Given this list of marker genes RPL21, sfaS, trxA, LTF, eis, botG, GTF2E2, TLR2, PRMT1, BECN1, CNBP, AP2M1, GBF1, DDOST, RPS15, ggtA, MED22, SNAP25, ANO5, esxA, TUBA4A, emrE, GNAT3, PSMC3, SV2C, UL114, PARP10, PACS1, MRC1, P4HB, ZDHHC11, RPS21, TRM1, FXYD7 (FXYD domain containing ion transport regulator 7), ARPC3, TAB1, SF3B2, ITCH, STT3A, UL41A, DDX20 (NCBI Gene Id 51452), RBX1, HERC5, POLR2D, RPS27 (NCBI Gene Id 6232), BCL2L1, MGAT4C, SPCS1, TAF4, PRR5, CAMK2D, UL4, TSG101, PPP1CC, ADCY4, AP1S3, bamD, CRB3, IGKV3D-20, UL48, SRSF3, mdfA, efeU, IGLV3-25, 16S rRNA, KPC-2, MVB12B (NCBI Gene Id 89853), IGLV8-61, SMAD3, MED6, LARP1, ANO2, GPC4, PYCARD, IGKV1D-16, MYO9B, ARID4B, BRMS1, feoB, IFNA6, CORO1A (NCBI Gene Id 11151), RPS4Y2, PPIH, RIPK3, CYSLTR1, vpr, DYNC1LI1, F2, RPS28, CBL, LY96, HNRNPU, TJP1, DHX9, FEN1, UL71, EIF4G2, CAMK2A, fepB, CDK7, IGHV4-34, ARID4A, lpdC, HLA-C, LIG1 (NCBI Gene Id 3978), US11, TRAF6, UL21A, bla, MED23, ptpA, hlyD, RPL36AL, ELMO2, GTF2A2, ARPC1B, AP1B1, trxB, UL94, GBP4, POLR2C, IL1A, ENTPD5, SRSF9, MAN2A1, ACTR2, SIGMAR1, CTSG, NEC1, MAPKAP1, 8, TAF11, NUP107, MYO10, LAMB3, secA1, RPL26L1, CTNNBL1, SNRPD1, ZDHHC8, AP2A1, SNRPD3, E, MED18, SMNDC1, H2BC17, RPL7, POLR2L, 8b, RPL22, TRIM27, ATG7, CDK8, 5.8S rRNA, ELAVL1, CCNK, inlA, lepB, IGKV1-16, mdtE, TUBA1C, RB1, CHERP (calcium homeostasis endoplasmic reticulum protein), RCOR1, 18S rRNA, GEMIN4 (gem nuclear organelle associated protein 4), SNRPB2, 1a, acrB, NCK1, IGKV3-15, NFKBIA, ZCRB1, SYT1, RPS23, TUBB2B, RNA4.9, SNF8, PSMA3, UL95, UL111A, SEC24D, RPL37A, 7SL RNA (ENSG00000222639), ADCY2, PROS1, exbD, US17, HCK (NCBI Gene Id 3055), VPS37D, HNRNPA3, VPS33B, IGLV1-36, FURIN, UL103, CHD3, ARF1, NOS2, UBA6, ntnha, CRNKL1, LPG1G2, CXCR4, ABI1, PLCG2, FIP1L1 (NCBI Gene Id 81608), SRSF6, NUP85, H2AC25, MAP2K2, GNAI2, YWHAZ, TBP, UBE2I, GNG3, CLDN1, VTN, RPLP0, MVB12A (NCBI Gene Id 93343), yqjI, IGHV4-39, GGT5, ARIH1, WAS, SUGT1, bfrB, RPS29, DYNLL2, TUBA3E, CSTF1, UL54, IMPDH1, CREB1, RBM10, PSMD3, BAG2, IFNA17, TAF3, nef, chuA, FXYD6, RPL38, MNAT1, PIK3R1, rpoA, PPP1CB (NCBI Gene Id 5500), SNRNP40, lef, CD163, tetX, PLK2, UL34, POLR2H, IGHV7-81, UL52, CHMP1A, UL9, PTK2 (NCBI Gene Id 5747), fecE, APOBEC3G, IGLV1-40, SNRPB, IFNA4, TUBA3D, IGKV3-20, CRK, LAMA3, PSMD13, TAF5, HDLBP, XAB2, efeO, RNF135, CUL5, RPL18, FXYD4, U2AF1 (NCBI Gene Id 7309), IGF1R, HDAC1, RPL27A, NFE2L2, UL147, IGKV5-2, JAK1, UL25, NCBP1, IGHV, NOD1, C4BPB, IFIH1, SLC25A5, IRF7, FXYD3, SFTPD, NUP54, UL92, GPC2, TBL1XR1, SNRPD2 (NCBI Gene Id 6633), PDPK1, ABI2, LAMB1, SUMO1, PHF5A, EXOC1, IGHV4-59, HLA-A, RAB5A, P2RX4, L, IFNA8, dppF, RPTOR, CWC27, MED28, IL6, GSDMD, fhuD, CCNT1, DYNLL1, SPCS3, RAE1, oppC, PRPF8, MED7, RPL41, SUN2 (NCBI Gene Id 25777), RPL3L, PHF21A (PHD finger protein 21A), NFKBIB, IGLV3-1, HMOX1, GPC6, RIR1, RNGTT, HLA-B, RPL4, rmtD, ERCC3, MLKL, MGAT4B, UL38, HA-33, dppC, IMPDH2, UL102, GGT1, HYOU1, SDC2, IGKV2D-40, dppB, CHMP5, SAP18, ENTPD1, PCF11, VPS41 (NCBI Gene Id 27072), TUBB4B, MED11, PDCD1, IFNA14, MED16, HLA-H, DPM3, trx-2, Hh5 strain Merlin complete genome, CALR, IGHG2, SYK, RPL32, P2RX7, RL11, PSIP1, IFNAR1, SEM1, rev, RPL13, NLRP3, MAP2K4, VAV2, IGHG1, H2AC11, UL148, REST, US20, znuC, US28, TUFM (NCBI Gene Id 7284), MERTK, TXNL4A, S, tonB, DHX15, GAS6 (NCBI Gene Id 2621), UL132, UL133, IGLV5-37, FNTA, H2BC13, HNRNPA2B1, MED1, PUF60, PPIL3, esxG, M, secG, PARP9, IGLV6-57, SUDS3, GTF2H4, AP1S2 (adaptor related protein complex 1 subunit sigma 2), FCGR2A, CD4, PPIL4, RPL7A, NS, RIPK2, RPL19, GBP1, fecB, IGLV2-11, rep, WASF2, BAIAP2, SF3B5, PPE2, SRRT, AHCYL1, ARPC1A (actin related protein 2/3 complex subunit 1A), gspS2, NUP214, WDR33, TAF1L, DYNC1I2, inlB, RPL12, SPCS2, UL70, ST3GAL4, HSPA1A, RPL24, IGKV2D-28, GATAD2A, PKLR, HNRNPL, MED9, GEMIN2, DYNLT1, CD28, US18, UL69, GNG4, CHMP4C, US24, XRN1, NUP188, MGAT5, ELK1, IGHV2-70, NCOR2, CCNT2, botA, HSPG2, RIPK1, RPS25, RL1, H2AC21, TAF6, NUP37, JAK2 (NCBI Gene Id 3717), SEC24C, AKT1, RPL10A, gB, glbN, PB1, TOMM70, aldR, IGHV3-30, ARPC4 (NCBI Gene Id 10093), TUBAL3, 7a, rmtC, LEO1, N, CLU, IGLV2-18, skp, ITPR3, UL32, RPL34 (NCBI Gene Id 6164), VPS28, DOCK2, IGHV3-9, sta2, CAMK2B, DHX38, bfr, NEDD4L, UBA52, TRX2, PRCC, IGKV3-11, H2BC9, PIK3R4, RPL23, tolC, irtB, rmtG, PSMA6, sodC, TRAF3, EEF2, SRPK1, IGLV3-12, ARPC2, 1C, EEF1A1, SH3KBP1, M2-1, GNGT2, CSNK1A1, PTBP1, MEFV, KPNA5, bamA, UL79, UBA5, RPS3A, UL44, IGLV1-51, TAF9, CPSF4, DPM2 (NCBI Gene Id 8818), RPL37 (NCBI Gene Id 6167), GPC3, PCBP1, ATG14, mdtF, KPNB1, MTA3, ahpD, US3, RPS6, IFNAR2, PRPF6, HBB, DOCK1, CD79A, CD2BP2, ITGB1, PSMC6, SDC4 (syndecan 4), COL4A3, PRKG2, AP1S1, NUP133, HLA-E, HSPA1B, UL84, gyrA, IGLV, GNB3, ybtP, NMT2, fhuC, VPS18, gspC2, RAB7A, UL88, CYSLTR2, KEAP1, ST6GAL1, CDK9, RPS27A, CBX1, SMN1, TXNRD1, UBB, GALNT1, RL10, MAPRE3, TRM3, RBM22, TGFB1, rpoC, RPL6, MED20, HNRNPH2, H2BC14, UBE2L6 (NCBI Gene Id 9246), GNG12 (NCBI Gene Id 55970), HNRNPR, SEC24B, FKBP4, NRBP1, US12, IGKV1D-12, DPEP1, IRAK2, C1QA, MTA1, NP, NCOR1, IGLC6, IGHV3-48, PSMD11, SEC11A, IRAK1, MGAT1, RCAN3, UL147A, LAMA2, NUP58, WASF1 (WASP family member 1), RPL39, RBBP4, DAD1, armA, MOGS, IGLV2-8, mppA, UBA7, BLNK, POLR2A, bcsQ, DUSP16, POLR2F, mdtA, VPS16, POLR2G, H2BC11, PSMB4, SV2B, NCKAP1, MED24, PA, UL74, 9b, NUP93, sta1, FCGR3A, IL17RA, MED12, POLR2E, gL, IFNA1, pef, PEX19, UL80, POLR2K, VPS45, IGKV2-30 (immunoglobulin kappa variable 2-30), ADORA2B, TRS1, GRPEL1, MAPK14, TUBB4A, IKBKG, surA, degP, UL122, CD8B, TBL1X, SEC11C, ITPR1, DYNC1H1, TAF15, SKP1, MED25, IGKV4-1, secD, NUP153, AQR, SH3GL3, PSMB2, ELAVL2, TAB3, UL22A, SH3GL1, H2AC6, US34, ANO6, H2BC5, ATP6V1H, SUPT4H1, HNRNPH1, H2AC7, GPC1, UL97, VPS11, UL99, RL8A, fecD, IGLV7-43, C4B, MED8, IL1B, TUBB1, ANO10, PRKAR1A, NCL, TUBB8B, SF3A1, IFNA10, secA2, GNB5, MT2748, RPS13, VPS25, IRS1, TLR6 (toll like receptor 6), RPL11, SV2A, MED17, OST4, US27, FXYD2, JAK3, RPL30, UL14, GSK3A, PARP1, VPS37C, ZDHHC3, PPIL6, TAF10, BUD31, VAV3, NELFE, NELFB, Rv3655c, MAP2K1, CCR5, CD209, CAMK2G, MAP1B, UL2, Human respiratory syncytial virus A, BRK1, ROCK1, YES1, RPS7, UL138, TIMD4 (NCBI Gene Id 91937), NUP42, PSMD12, PSMD14, KPNA7, PARP6, STT3B, TAF1 (TATA-box binding protein associated factor 1), NMT1, rmtH, CTNND1, SRRM1, NUP50, NOX1, ahpC, NPM1, BTK, TLR4, GNB2, Rv2895c, PPIE, IFNGR1, TMPRSS2, MAP2K3, GTF2F2 (NCBI Gene Id 2963), MED4, DPM1, RL9A, PABPN1, RPL31 (ribosomal protein L31), GTF2H5, RCC1 (NCBI Gene Id 751867), PSMB7, mdtB, US2, RBBP7, bamC, RPL9, CYFIP1, CPSF2, H2BC15, RPL26, CHMP2A, B2M, CHMP4A, CLP1, AXL, 5S rRNA, RICTOR, GBP2, csgA, GNGT1, COL5A2, rpoZ, UL82, MED21, POLR2I, PSMA7, CWC15, IGLV7-46, MED10, PTPN11, CLINT1 (NCBI Gene Id 9685), fkpA, PRPF19, BCAP31, MTA2, NOD2, fes, UL5, H2BC21, DYNC1I1, ADRM1, DNAJC8 (DnaJ heat shock protein family (Hsp40) member C8), TUBB3, TCEA1, IGLV3-16, RPL23A, PABPC1, UL16, VPS37A (VPS37A subunit of ESCRT-I), MED14, COL4A5, SAR1B, VPS4A, WIPF3, ZDHHC5, UTI89_C2180, RPS14, RBMX, EIF4E3, Rv3654c, P4HA1, H2AC14, vpu, DAXX, NT5E, YWHAE, U2AF1L4, BTF3, nleF, TUBA8, oppB, TUBA3C, IL10, PSMC2, SF3B4, CCNH, cya, GTF2A1, acrD, tat, pagA, CD247, GBP6, ha17, TLR9, NUP205, CX3CR1, 1B, tetA, TAOK1, GNG8, fecA, COL4A2, IGHV2-5, UBE2V1, IFNA21, gM, XRCC5, DNAJC3, VPS4B, WBP11, EIF4A2, CHMP3, IGLV4-60, NELFA, GNB4, RPS19, 28S rRNA, SEH1L, PLCG1, DNAJA2, UL23, GRSF1, UL124, PSMD7, PAF1 (NCBI Gene Id 54623), CWC25, UBR4, TLR8 (toll like receptor 8), STAT2, UL146, RPS8, CLTC, MASP1, gdx, EIF4G3, VTA1, ALYREF, MET, IL17RC, TRX1, GTF2F1, SUZ12, UL112/UL113, UVRAG, eltB, ISG15, CHMP6, FUT8, oppD, CDH1, RPL8, APOA1, mdtC, fepD, HNRNPF, UL18, C4A, US10, IGHV3-53, EIF4A1, IGHV1-69, IFNGR2, STX1A, CHMP2B, IGHV3-7, EIF4G1, DVL2, H2BC3, exbB, bcsA, CRBN, PSMA5, TPR, PRKCSH (PRKCSH beta subunit of glucosidase II), IGLC1, VEGFA, ATP1A4, PRKACG, DENCMEMSB, ARPC5, RPS20, US26, TAB2, DVL3, NCBP2, GTF2B, DBP, ANO9, rpoB, CVC1, NUDT21, UL11, hlyA, HNRNPC, H2BC1, TAF2, XRCC4, ACTR3, IL17A, ATP1A1, RPL28, PPIB, ST3GAL1, IGLV2-33, H2BC18, SMAD4, IGHV1-46, HSPA5, H2AC20, SUPT5H, TXNIP, KDM1A, ATL2, MAPK3, DNAJC10, ANTXR2, TAF8, NCKIPSD, PML, pstS1, ANO1, SRSF11, blaSHV-12, CALM3, VPS39, CCAR1, MAP3K7, GUCY2C, KPNA2, TYK2 (NCBI Gene Id 7297), RPS10, RPSA, NUP210, esxH, TKFC, TAF9B, PSMB5, sapM, ADCY9, KDELR1, NEC2, C3, F, RPS17, 7SL RNA (ENSG00000222619), UL15A, GNG13, CASP1, CTR9, FN1, CLTA, SRSF2 (serine and arginine rich splicing factor 2), SEC23A, UBC, PPIL1, DYNC1LI2, MAGT1, IPO7, GNAI1, TMEM258, bamE, MMP9, RPL10, IGKV1D-33, dppA, EMC4, ACE2, PSMB1, UBE2D2, RBM17, H3C1 (NCBI Gene Id 8350), CHD4, UL91, H3C15, PATJ, ANO8, ANTXR1, EED, ELOB, TUBA1A, RIGI, GBP3, AUP1, SRRM2, UPK1A, ST6GALNAC2, GTF2H1, RAB5C, sta3, NELFCD, RPL29, S1PR1, SERPINE1, GATAD2B, PRKAR1B, TAF7, tpx, TRIM28, GNG5, lprG, gyrB, RPL14, bcsG, hlyB, DDX23, SNRPN, gspD2, IKBKB (NCBI Gene Id 3551), GTF2H2, SDC1, CHMP4B, ELL, UL43, SUGP1, RPS15A, VPS33A, SNRPF (small nuclear ribonucleoprotein polypeptide F), MLST8, IGKV1-12, CDC42, ACTB, IGKV1-39, STAM, NUP62, UL104, ZDHHC20, CSNK2B, GNAZ, NS5B, fepA, secY, NACA, HNRNPA1, IFNA16, RNMT, FKBP1A, RPL22L1, XPO1, LAMC1 (NCBI Gene Id 3915), NUP43, CPSF1, PTGES3, ELOA2, tetB, H2BC12, NDC1, YBX1, TAF7L, VCP, H2BC26, IPO5, LCK, secA, MED26 (NCBI Gene Id 9441), fimH, IGLV5-45, TUBB6, ROCK2, H2AC1, rmtF, NOXO1, HLA-F, mrcB, EGFR, H2AC12, ADCY8, UL98, papGI, rrsA, macA, entS, US32, NMI, CHUK, H2AC18, IGKC, RPS18, RANBP2, ISY1, RAC1, AKT3, CLEC5A, TUBA1B, MAPK1, SFPQ, FASN, ISCU, NPIPB3, pp1a, RRBP1, ITPR2, GNAS, G, MAP2K6, WASF3, PSMC4 (NCBI Gene Id 5704), gag, rmtB, COL4A4 (NCBI Gene Id 1286), GJA1, DHX16, CLEC4M, CDC40, GTF2E1, U2SURP, IGLV1-44, EIF4A3, COL4A1, MBD3, EIF2AK2, SF3A3, NA, TUBB, EP300, HSPA8, PQBP1, VAMP1, CAV1, AP2B1, RNASEK, UL26, PTPN6, CWC22, PDIA3, SYMPK, MYH2, NLRP12, MED30, NUP98, RPS16, VAV1, GEMIN5, SNRPG, PRKAR2B, CDK19, LY6E, RPS4X, PPP1CA, macB, ahpE, WIPF1 (WAS/WASL interacting protein family member 1), IGHM, UFD1, MASP2, G3BP2 (NCBI Gene Id 9908), SNRPE, EZH2, IGLV3-22, RPL39L, PPIG, secE, dppD, botD, SP1, IL17F, CYBA, US34A, adhE2, LAMA5, CASP4, BST2, HNRNPUL1, US33A, AKT2, STAT1, PARP8, RNPS1, UBAP1, POM121, ACTG1, IGHV3-33, yhjR, IGHV3-13, HELI, draE, US23, efeB, POLR2B, MED31, AP2A2, G3BP1, US9, UBE2N (NCBI Gene Id 7334), IGLV4-69, MAP1LC3B, GEMIN6, RPS5, SCAP, IGKV1D-39, LAMC2, SF3A2 (splicing factor 3a subunit 2), IGLV2-23, ipaH9.8, ADCY1, IGLC7, UL31, NCKAP1L, CD300A (CD300a molecule), fepG, IFNA2, PRKACA, AP1M1, ST3GAL2, IGHV3-11, WIPF2, PARP16, RPS2, RBM5, HMGA1, IGLV1-47, bamB, oqxA, MCP, ADCY3, 6, PSTPIP1, PRKAR2A, UBA1, ADCY7, SAP30L, PSMD1, EPCAM, MAP2K7, NUP88, vif, RETREG1, CTNNB1 (NCBI Gene Id 1499), fepC, ha70, SNW1, FNTB, MYO5A, IFNA7, RPL35A, TAF12, P, MAVS, PSMD2, SDC3, ELMO1, RHBDF2, SRSF4 (NCBI Gene Id 95902), RPS27L, FUS, Human respiratory syncytial virus A2, complete genome, BANF1, YWHAQ, UL83, SNRPA1, BTRC, NUP155, HGS, MED27, HLA-G, PB2, LYN, CBLL1, IGKV2-29, CSTF3, IGHV3-23 (NCBI Gene Id 28442), CD3G, ACOT2, PAK2, TAL1, RAB5B, AP2S1, IGLV3-19, IGLC2, NR3C1, PIK3C3, SUPT16H, NEK2, secF, ST6GALNAC3, MED19, SIKE1, MED13L, COL5A3, SOS1, RELA, COG1, M2-2, UL87, RPL36A, US13, SEC13, dlaT, SLC25A4, TYRO3, hlyE, RPS4Y1, FAU, H4C1, IGHG3, UL24, COL4A6, bcsC, BRD4, PALS1, PSMD8, AP1M2, CDC73, FCGR1A, HDAC3, ndkA, qnr, NRP1, TUBB2A, VPS37B, CGAS, TRIM4, DPEP2, gN, TRM2, US14, CEBPD, STAM2, CALM2, UL29, UL144, UL130, TBK1, botF, SSRP1, MAPK8, Rv1410c, ELOA, VPS36, PSMA2, GNG10, RANBP1, SH, RPS3, IL6R, ADCY6, IGLV3-27 (NCBI Gene Id 28791), OSTC, CUL3, UL117, IGLV2-14, SRC, TLR3, IGLV11-55, ospC3, IGKV2-28, HNRNPK (NCBI Gene Id 3190), EDEM2, RPS9, IGLV10-54, msrA, P4HA3, MGAT4A (alpha-1,3-mannosyl-glycoprotein 4-beta-N-acetylglucosaminyltransferase A), UBA3, AP1G1, MAN1B1, FYN, IGKV1-5, gag-pol, SF3B1, SFN, FZD7, SRPK2, RPL36, IGHV1-2, HSP90AB1, JUN, COL5A1, MBL2, CHMP7, RPS24, RPL18A, fgd1, SYT2, WNT5A, UL96, PLRG1, fhuB, NOXA1, GSK3B, IGHD, RPL17, RPL35, C3AR1, ZDHHC9, NUP160, ATP1B3, GRB2, ANO3, LAMB2, UL37, sodB, hbp, RTF1, IGLV3-21, KPNA4, znuA, RPL3, NUP35, TLR7, LAMA4, IGHG4, NHERF4, IL18, EFTUD2, MED13, CD9, CSNK2A2, NFKB2, GEMIN8 (NCBI Gene Id 54960), bcsE, CSNK2A1, env, eltA, SRSF7, NPLOC4, YWHAH, UL120, FXYD1, IL1R1 (interleukin 1 receptor type 1), HAVCR1, TUBA4B, SCP, SF3B6, DVL1, TLR1, RTN3, HA, MYO1C, UL131A, PCBP2, STING1, KPNA3 (NCBI Gene Id 3839), UL17, POLR2J, HNRNPD (NCBI Gene Id 548), CPSF7, ITGA4, HBA1, FGR, GEMIN7, CYFIP2, NFKB1, oppA, PSMD6, CVC2, RPLP2 (ribosomal protein lateral stalk subunit P2), botB, YWHAG, AAC(6')-Ib, ADAM17, UL78, MYH9, UL7, IGKV1-17, RPS12, SARS coronavirus, complete genome, SLC25A6, DNAJB11, C4BPA, PSMC5, hly, ST3GAL3, GNG7, 3b, XRCC6, RANGAP1, SNRNP200, ADCY5, MED15, OAS2, UL119/UL118, H2BC4, C1S, IGKV1-33, POM121C, HBEGF, PARP14, LIG4, CPSF6, ZBP1, STX1B, HDAC2, GPS2, IGLC3, CD14, IGKV2D-30, SRSF1, H2AC4, PSMB6, SKIC8, RUNX1 (RUNX family transcription factor 1), RPN1, GNAI3, CANX, ATP1A2, RPL13A, DDX3X, UL13, lprM, GOLGA7, TXN, katG, irtA, ELOC, LAMA1 (NCBI Gene Id 3907), CREBBP, CD33, ATP1B1, UL123, HMG20B, MGAT2, PAPOLA, RAN, fecC, UL121, dsbA, COMT, RPL15, VIM, SH3GL2, cpnT, acrA, US16, GNG11, PRKX, TAF4B, PRKACB, YWHAB, PSMA1 (proteasome 20S subunit alpha 1, NCBI Gene Id 5682), PPIA, ANO4, yqjH, TUBB8, MTOR, US22, GNB1, CD79B, ERCC2, RPN2, RPLP1, UL36, SAP30, PSMA4, IKBKE, VHL, US30, PDCD6IP, PGK1, gH, AGRN, WASL, RPL27, TUSC3, RPL5, ABL1, MED29, VAMP2, DDX42, UL35, espC, GPC5, EPS15, CDC5L, HSP90AA1, DDX5, IGLV4-3, CTSL, DDX46, PARP4, ST6GALNAC4, IFNA5, bcsB, Rv3364c, znuB, US19, BCAS2, RPS26, ANO7, LAMC3, U2AF2, ATP1B2, US8, APP (NCBI Gene Id 351), HNRNPM, RPL10L, UL27, SEC24A, GTF2H3, TRIM25, SF3B3, CCNC, CTDP1, RNF213, RPS11, P4HA2, ATP1A3, CALM1, CSTF2T, PRKG1, mrkD, TAF13, GPKOW, fyuA, ENO1, iutA, EIF4E, ZDHHC2, PSMC1, IFNB1, 3a, KPNA1, UL47, IRF3, GNG2, AAAS, DUT, CSTF2, CPSF3, PSMB3, HNRNPA0, GANAB, feoA, SRSF5, botE, UL76, here is a description of the gene set: studied in species Homo sapiens Reactome Pathway: Infectious disease part of: Disease Infectious diseases are ones due to the presence of pathogenic microbial agents in human host cells. Processes annotated in this category include bacterial, viral and parasitic infection pathways.<br><br>Bacterial infection pathways currently include some metabolic processes mediated by intracellular Mycobacterium tuberculosis, the actions of clostridial, anthrax, and diphtheria toxins, and the entry of Listeria monocytogenes into human cells.<br><br>Viral infection pathways currently include the life cycles of SARS-CoV viruses, influenza virus, HIV (human immunodeficiency virus), and human cytomegalovirus (HCMV).<br><br>Parasitic infection pathways currently include Leishmania infection-related pathways.<br><br>Fungal infection pathways and prion diseases have not been annotated.